Given this list of marker genes Sh3glb1, Tmem108, Spry2 (NCBI Gene Id 24064), Ppp2r5b, Spry1, Ulk1, Slc9a6, Cyfip1, Dok5, Wasf1, Ppp2r5d, Ngf, Agtr2, Ptprf, Agt, Zdhhc17, Cyfip2, here is a description of the gene set: Any process that modulates the frequency, rate or extent of the neurotrophin TRK receptor signaling pathway. species: Mus musculus Mouse Gene Set: GOBP_REGULATION_OF_NEUROTROPHIN_TRK_RECEPTOR_SIGNALING_PATHWAY